The following is a description of a gene set: The process in which amyloid-beta is removed from extracellular brain regions by cell surface receptor-mediated endocytosis, followed by intracellular degradation. species: Homo sapiens Human Gene Set: GOBP_AMYLOID_BETA_CLEARANCE_BY_CELLULAR_CATABOLIC_PROCESS, and this is the list of marker genes: CD36, ABCA7, MME, IDE, TREM2, LRP4, LRP1, LDLR